The following is a description of a gene set: Mouse Gene Set: GOBP_DORSAL_VENTRAL_AXIS_SPECIFICATION The establishment, maintenance and elaboration of the dorsal/ventral axis. The dorsal/ventral axis is defined by a line that runs orthogonal to both the anterior/posterior and left/right axes. The dorsal end is defined by the upper or back side of an organism. The ventral end is defined by the lower or front side of an organism. studied in species Mus musculus, and this is the list of marker genes: Senp2, Bmpr1a, Axin1, Smad2, Wnt3, Mdfi, Axin2, Smad6, Ctnnb1, Lrp6, Pax6, Sfrp1, Vax2